Given this list of marker genes Nlrc5, Mas1, Prdx2, Grn, Atat1, Lyplal1, Ets1, Ccr7, Peli1, Ticam1, Fpr-rs3, F2, Ajap1, Rnf185, Trim45, Ercc6, Hspa8, Pla2g5, Il15, Gpsm3, Anxa5, Ythdf2, Pdgfd, Itch, Slamf6, Wnt4, Grem1, Nfe2l1, Rnf170, Creb3, Cd55b, Dtx4, Trim21, Atm, Usp17le, Bst1, Tubb2b, Pde5a, Polr3c, Smpdl3a, Slc8b1, Gata6, Gbp2b, Tut4, Xylt1, Zdhhc11, Cma1, Cdh13, Nlrp14, Syk, Sh2b3, Xiap, Cmklr1, Ap1g1, Tab1, Socs3, Il2ra, Tnf, Plaur (NCBI Gene Id 18793), S100a8, Hspa1b, Stat5a, Lta, Git1, Il12b, Mdga1, Spn, Brcc3, Gper1, Ptger3, Vegfd, Rgma, Csf1, Myo1f, Nkg7, Ifi208, Nrxn1, Bcr, Tlr5, Fabp7 (fatty acid binding protein 7, brain), Ceacam1, Zbp1, Tradd, Cttn, Cyp19a1, Smpdl3b, Psmb4, Phb2, Nupr1, Peli3, Ccl5, Mir675, Ncf1, Klrb1, Ptger4, Htr2a, Ufd1, Ivl, Ccr4, Ywhae, Nlrp1a, Klri2, Prkd2, Znfx1, Adipoq, Tnfaip8l2, Irgm1, Tnip3, Pja2, Cd28, Tspan6, Ahsg, Lamp2, F11, Sharpin, Cxcl12, Tbc1d23, Tnfaip3, Myoz1, Ppm1f, Mmp12, Nlrp9a, Ccl21d, Ppp1r13l, Mark4, Snai2, Camk1d, Oas1g, Mospd2, Gpr4, Hexim1, Il18, Cd44, Plcg2, Ly96, Ubash3b, Trim62 (tripartite motif-containing 62), Hopx, Dhx33 (DEAH-box helicase 33), Fgf18 (NCBI Gene Id 319384), Wnt3, Sema7a (NCBI Gene Id 78407), Pglyrp2, Inpp5d, Ppp6c, Cfh, Ulbp1, Fem1a, Ntrk3, Socs5, Cyba, Tspan8, Nono, Abcc1, Ilrun, Gsdmd, Tnfrsf11a, Cpt1a, Serpinb9h, Pglyrp1, Gbp2, Aoah, Ndfip1 (Nedd4 family interacting protein 1), Cd300a, Colec12, Klkb1, Serpinb9e (serine (or cysteine) peptidase inhibitor, clade B, member 9e), Pum1, Ubqln1, Clasp1, Slit2, Tnfsf18, Cd226, Adam10, Spi1, Extl3, Adora2a, Nbl1, Il17a, S100a9, Lgals2 (NCBI Gene Id 66535, lectin, galactose-binding, soluble 2), Trim31, Thbd, Nedd9, Pdgfb, Trim56, Abr, Drd2, F2rl1, Clcf1, Ednra, St6gal1, Ttll12, Lyar, Ldlr, Serpinb9c, Rhbdd3, Ltf, Eif4e2 (eukaryotic translation initiation factor 4E member 2), Inpp5f, Epha4, Dscam, Mfhas1 (malignant fibrous histiocytoma amplified sequence 1), C2cd4b, Cd109, Lpcat3, Vamp8, Bmpr2, Lrfn5, Ecsit, Ccl21e, Hrg, Ctla2a, Il27, Dhx9, Tlr6, Ntf3, Nlrp3, Trim44, Gramd4, Cx3cl1, Cgas, Letmd1, Cfhr4, App, Srebf1, Sash1, Casp1, Bcl10, Nlrc4, Elf4, Gkn2, Wdfy1, Tbr1, Fcgr3, Brcc3dc, Tafa3, Cxcl5, Lrrk2, Rbm47, Igtp, Wnt3a, Tac1, Ripor2, Cebpb, Lilra5, Lats1, Lep, Mmrn1, Epg5, Robo3, Il1b, Grk1, Arg2, Nppa, Map2k2, Tafa5, Ddx39a, Il12rb1, Fgg, Smoc2, Gpr31b, Pml, Lpar1, Gm12250, Cx3cr1, Ccn3, Vegfc, Zdhhc1, Vwf, Ifi206, Ccl2, Dnm1l, Nod1, Ifnlr1, Rnf26rt, Prkca, Polr3b, Fndc4, Zdhhc3, Spsb3, Rnf31, Ptgr1, Psg23, Ppm1b, P2ry12, Il17rb, Trim30b, Vegfa, Fancd2, Nr5a2, Clec12b, Tnfsf14 (tumor necrosis factor (ligand) superfamily, member 14), Tlr13, Dnase1, Camk2n1, Drosha, Dnase1l3, Tmem102, Efnb2, Ptpn22, Usp38, Arnt, Btk, Samhd1, Fadd, Gbp7, Tlr3, Cxcl14, Zc3h12a, Cep63, Clec4e, Znrf4, Krt1, Sema5a, Adar, Trim41, Gbp4, Casp8, Ripk2, Ifih1, Agt, Arrb2, Serpinb9b, Pik3ap1, Tpbg, Dapk2, Calhm6, Lrp8, Alpk1, Shpk, Tyro3 (NCBI Gene Id 98916), Oas1h, Fut7, Ppbp, Rac2, Gjd4, Zc3hav1, Lsm14a, Ythdf1, Lrsam1, Plxna4, Trafd1, Serpinb9, Tlr11, Ddx3x, Src, Sfpq, Polr3f, Nlrc3, Lats2, Grin1, H2-T23, Mkrn2 (NCBI Gene Id 97310), Acp5, Trim5, Nrg1, Pla2g3, Gfer, Evpl, Nectin2, Il12a, Cd300lf, Mycbp2, Anxa2, Trem3, Klrb1f, Rab7b, Pik3cg, Brd4, Gp1ba, Mdk, Irak3, Traf6, Pla2g7, Park7, Usp29, Serpine1, Wfdc1, Pomc, Mill1, Elmod2, Trib1, C1qtnf3, Tifab (NCBI Gene Id 212937), Fxr1, Tmx1, Pdcd10, Clnk, Cacnb3, Adamts12, Cd300c2, Pgf, N4bp1, Metrnl, Serpine2, Stk24, Scimp, Myod1, Il21, Cxcr2, Ereg (epiregulin), Tyrobp, Fga, Plscr1 (NCBI Gene Id 54533), Mapk3, Sod1, Prkd1, Cers2, Slc15a3, Parp1, Pf4, Nlrp4a, Oas1a, Lpl, Alox15, Ccl19, Apoh, Klre1, C5ar1, Selenos, Sell, Scarf1, Mir147, Traf3, Znrf1, Map3k7, Hmgb1, Swap70, Ucn, Cd37, Adora2b, Polr3g, Spata2 (NCBI Gene Id 263876), Sucnr1, Prkdc, Trim12a, Mapkapk2, Oas1e, Il22b, Flot1 (NCBI Gene Id 14251), Nectin4, Npy5r, Gprc5b, Pros1, Gpr17, Stat3, Tkfc, Gbp5, Ghrl, Dpp4, Ins2 (NCBI Gene Id 16334), Reg3a, Nploc4, Cyld, Sarm1, Nlrp5, Tmem126a, Fcer1a, Kng1, Arel1, Celf1, Calr, Chd8, P2rx4, Bpifb1, Crk, Pum2, Nlrp4f, Trim11, Ighg1, Ash1l, Ffar2, Cd200l2, Irak1, Casr, Cpb2 (carboxypeptidase B2), Mmp28, Ifi213, Atoh7, Nt5e, Nlrp2, Cptp, Igf1, Il33, Csnk1a1, Slc12a2, Optn, Fabp4, Hgf, Ffar3, Rnf216, Ghsr, Abhd12, Cd300e, Cd200r3, Dusp1, Mir7578, Lgals9, Enpp4, Nlrx1, Cxcr4, Snca, Adam8, Pdcd4, Nlrp9b, Ada, Dtx3l, Gfi1, Fgf10, Nckap1l, Lgmn, Ccr6, Il22ra1, Tnfrsf1b, Tspan32, Rarres2, Mcu, Gpx2, Mst1, Ogt, Igf1r, Emilin1, Tlr7, Vtn, Ifi204, Lag3, Chrna7, Hspb1, H2-M3, Nop53, Robo2, Plau, Tasl, Met, Serpinb9f, Braf, F2r, Gpx1, Hc, Zdhhc4, Il1rl2, Irgm2, Prkce (NCBI Gene Id 98094), Zdhhc18, Pmp22, Sertad3, Sh2d1b1, Cnot7, Gimap3, Mapk1, Nr1h4, Usp50, Cd36, Gp5, F12, Pcbp2 (poly(rC) binding protein 2), Usp15, Grb2, Arg1 (arginase, liver), Tlr1, Vps35, Nlrp1b, Zfp36, C3ar1, Zp3, Ccl19-ps6, Smad3, Vav1, Cd300ld3, Sfn, Fam76b (family with sequence similarity 76, member B), Ido1, Il16, Trim32, Zfp580, Foxp1, Naglu, Akna, Il22ra2, Trem2, Pycard, Plg (plasminogen), Ptk2, Oasl1, Ffar4, Tril, Pik3r6, Sqstm1, Capn3, Cd200r4, Tap2, Tiam1, Map2k1 (mitogen-activated protein kinase kinase 1), Cd96, Tbk1, Pgc, Akirin2 (akirin 2), Gps2, Trim3, Pde2a, Ppp2ca, Fezf2, Riok3, Ccl19-ps3, Apoe, Crtam, Cd200r2, Fgb, Igf2, Ifi205, Map3k8, Tlr2, Cxcr3, Zdhhc12, Stat5b, Cactin, Foxa2, Il34, Sin3a, Tnfsf11, Mmp8, Tnfsf4, Irf1, Hcfc2, Ccr1l1, Alox5, Pdgfa, Akt2, Fpr-rs4, Kcnn4, Polr3d, Rasgrp4, Fam3a, Sbno2, Med1, Grid2, Ccl7, Serping1, Drd3, Xrcc6, Pqbp1, Il10ra, Muc19 (mucin 19), Mapkbp1, Ano6 (NCBI Gene Id 73015), Csf1r, Tff2, Sema3f, Il22, Clasp2, Card9, Mapkapk3, Ryk, Ifi207, Ttbk1, Psma1, C3, Raet1e, Cd81, Sirpa, Xcl1, Aars2, Gdi1, Nlrp10, Atg12, Fkbp1b, Nr1h5, Adtrp, Grin3a, Gata3, Bmp6, Unc93b1 (NCBI Gene Id 54445), Serpinc1, Akt1, Treml4, Ccl19-ps4, Il23a, Pspc1, Cd84, Stx3, Ctnna2, Rbm14, Ticam2, Vkorc1, Cd47, Defb21, Chuk, Ripk1, Fbxl2, Aipl1, Tnfaip6, Usp14, Rela, Rin3, Lbp (NCBI Gene Id 16803), Inava, Appl1, Nr1h3, Mif, Defb25, Sirt2, Oas3, Ifi35, Adam17, Lrrfip2, Ikbke, Plat, Trpv4, Rb1, Cd160, Appl2, Slamf8, Ly86, Fcer1g, Fgf4, Fpr-rs6 (formyl peptide receptor, related sequence 6), Aoc3, Tomm70a, Ifna1, Dhx58, Perp, Il18rap, Snx4, Fgl2, Ccl21a, Trim12c, Nr1h2, Erbin, Fcnb, Tlr12, Wnt5a, Ptpn11, Rab34, Ccl21b, Lacc1, Gpr18, Ccl21f (C-C motif chemokine ligand 21F), Scgb1a1, Ube2k, Dab2ip, Ptk2b, Armh4, Mpp1, Il2, Tbxa2r, Clock (NCBI Gene Id 620729), Ednrb, Lrrc14, Shh, Tnc, Dbn1, Cdc37, Pla2g2d, Mbl2 (mannose-binding lectin (protein C) 2), Padi2, Slc6a3, Nr1d1, Kcnk13, Coro1b, Rab11fip2, Enpp3, Cebpa, Rtca, Fn1, Ythdf3, Lrch4, Pdgfrb, Washc4, Tlr9, Rora, Isg15, Trim38, Nagk, Trim30a, Klrd1, Trim30c, Irf3, Txk, Clec7a, Cd55, Nmi, Itga2, Ccl12, Ighg2b, Oas1b, Nod2, Jam3, Cd200, Ctsc (NCBI Gene Id 13032), Ccl26, Dusp3, Sh2d1b2, Macir, Il1rl1, Tifa, Ptn (NCBI Gene Id 19242), Pik3r1, Il17f, Klrb1a, Hyal2, Mgll, Cd9, Calhm2 (NCBI Gene Id 72691), Mtus1, Lyn, Rps19, Aph1c, Apobec3, Drd1, Prkg1, Rigi, Edn3, Selenok, Ifng, Gimap5, Duoxa2, S100a14, Zmpste24, Cadm1, Acod1, Rictor, Edn1, Ptgs2, Akirin1, Ndel1, Tax1bp1, Tnip2, Lrrc19, Lgr4, Nr1d2, Cd200r1, Esr1, Mavs, C1qtnf12, Sting1, Ephb2, Cd200l1, Pbk, Gm15441, Dusp10, Stk39, Tgfb1, Tap1, Nfkbia, Ifi209, Rnf115, Omg, Muc16, Klk5, Aurkb, Ccr5, Stx4a, Mvk, Hamp, Il1r1 (interleukin 1 receptor, type I), Eif2ak4, Fcgr1, Slamf1, Ptgis, Ccr2, Fgf16, Klrk1, Ptges, Trim30d (NCBI Gene Id 209387), Fosl1, Casp3, Il10 (interleukin 10), Trim25, Wasl, Adamts18, F7, Tfpi, Cldn3 (claudin 3), Cask, Hdac6, Nfe2l2, Irf2, P2rx7, Htra1, Ncr3-ps, Hspd1, Ccl3, Traf3ip3, Ier3, Klf4 (NCBI Gene Id 269540), Il6, Xrcc5, Slit1, Myd88, P2rx5, Spaar, Rnf125, Adora1, Sema3a, Abhd17a, Cd24a, Gstp1 (glutathione S-transferase, pi 1), Dcst1, Mcph1, Oas1d, Cd14, Kdr, Ccl19-ps5, Rnf26, Sec14l1, Rtn4, Proc, D130043K22Rik (NCBI Gene Id 78157), St3gal4, Slc15a2, Cd300c, Dvl1, Ifi203, Kars1, Bcl6, Klri1, Tirap, Gas6, Rps6ka3, Cst7, Anxa1, Slc39a8, Nfkb1, Atg5, Slc46a2, Ppp2r3c, Tmprss6, Kat5, C5ar2, Hpse, Ppara, Klk7, Setd4, Ywhaz, Alox12, Neo1, BC037156, Fcna, Pvr, Zdhhc9, Isl1, Cxcl10, Mmrn2, Casp12, Oxsr1, Sbno1, Mettl3, Setd6, Usp27x, Ifi214, Cd180, Npy, Gpatch3, Fgr, Ninj1, Gbp3, Kng2, Trem1, Pparg, Gpr183, Cyrib, A2m, Apoa1, Ddx60, Agrn, Rsad2, Adora3, Tnfrsf1a, Dysf, Nlgn3, Slc7a2, Cav1, Sh2d1a, Ankrd17, Ufl1, Il20rb, Pdgfra, Matr3, Tlr8, Stat2, Dsg2, Alox5ap, Syt11, Ipo5, Fcgr2b, Fpr2, Ccl1, Ins1, Aph1b, Stap1, Mul1, Robo1, Sox15, Serpinb9d, Cnr1, Klrc1, Cxcl13, Rftn1, Eppk1, Irak2, Hpx, Traf3ip1 (TRAF3 interacting protein 1), Rasgrp1, Cxcl17, Susd4, Napepld, Irf7, Cxcl1, Elp6, Hsp90aa1, Thbs1, Ccn4, Dicer1 (dicer 1, ribonuclease type III), Tnr, Pdpk1, Trex1, Ccl24, Ptprs, Aim2, Nlrp4b, Bcl6b, Trim15, Trim6, Angpt2, Nlrp4c, Clec4n, Tlr4, Lrp1, Cldn19, Bap1, Cntf, Lamp1, Notch1, Fgf1, Lrig2, Nek7, Dagla, Emilin2, Il4, Pim1, Unc13b, Tnip1, Zcchc3, Dnaja3, Ptprf, Zdhhc5, Trim65, Ptpn2, Nt5c2, Ptgs2os, Klrc2, Kif21a, Mefv, Slc15a4, Wnk1, Rac1, Nlrp9c, Stat1, Becn1, Vsig4, Ccr1 (C-C motif chemokine receptor 1), Mstn, Gigyf2, D1Pas1, S1pr1, Raet1d, Tarbp2, Slc19a1, Ahr, Megf8, Ap3b1, Ppard, Fem1al, Edn2, Serpinb9g, Rnf144a, Casp6, Pla2g10, Jak2, Eif2ak2 (NCBI Gene Id 76759), Kcnj8, Cd274, Hspa4, Usp18, Siglecg, Fanca, Pou4f2, Fgf2, Osm, Adcyap1, C2cd4a, Nlrp4e, Ggt1, Cdh5, Havcr2, Il23r, Ptprj, Nlrp12, Artn (artemin), Tslp, Ifnb1, Otulin, Phb1, Ager (advanced glycosylation end product-specific receptor), Serpinb1a, Ifi211 (interferon activated gene 211), Drd4, Clpb, Rnf34, Ppt1, Adgra2, Uaca, Parp9, Ctss (cathepsin S), Nrp1, Kremen1, Ccdc134, Vegfb, Rtn4r, Lgals1, Parp14, Clec2d, Flna, Ppl, C1qbp, Cd86, Fpr-rs7, Nfkbiz, Oas1f, Klrc3, Tmsb4x, Cd74, Foxf1, Bace1, Irf4, Siglece, Foxp3, Banf1, Klrb1c, Arf6, Hmgb2, Klrb1b, Reg3g, Il13, Tpsab1, Smim30, Casp4, Il17ra, Phldb2 (NCBI Gene Id 547265), Nfkbil1, Stmp1, Mndal, Scg2, Rnf135, Fgfr1, Gpr108, Oas1c, Ccl19-ps1, Gstp2, Sphk1, Aif1, Ptpn6, Mapk8, Plxna3, Otud4, Rabgef1, Prkcd, Nlrp6, Otop1, Thbs4, Ifi203-ps, Traf3ip2, Nova2, Cd276, Serpinf2, Clec12a, Ddt, Pten, Rtn4rl1, Daglb, Duoxa1, C1qtnf1, here is a description of the gene set: Any process that modulates the frequency, rate or extent of a response to an external stimulus. Mouse Gene Set: GOBP_REGULATION_OF_RESPONSE_TO_EXTERNAL_STIMULUS studied in species Mus musculus